The following is a description of a gene set: An array of kinases catalyze the reversible phosphorylation of nucleotide monophosphates to form nucleotide diphosphates and triphosphates.<p>Nucleoside monophosphate kinases catalyze the reversible phosphorylation of nucleoside and deoxynucleoside 5'-monophosphates to form the corresponding nucleoside 5'-diphosphates. Most appear to have restricted specificities for nucleoside monophosphates, and to use ATP preferentially (Van Rompay et al. 2000; Anderson 1973; Noda 1973). The total number of human enzymes that catalyze these reactions in vivo is not clear. In six cases, a well-defined biochemical activity has been associated with a purified protein, and these are annotated here. However, additional nucleoside monophosphate kinase-like human proteins have been identified in molecular cloning studies whose enzymatic activities are unknown, and several distinctive nucleoside monophosphate kinase activities detected in cell extracts, e.g., a GTP-requiring adenylate kinase activity and one or more guanylate kinase activities have not been unambiguously associated with specific human proteins.<P>The nucleoside monophosphates against which each of the six well-characterized enzymes is active is shown in the table (Van Rompay et al. 2000). All six efficiently use ATP as a phosphate donor, but have some activity with other nucleoside triphosphates as well in vitro. The high concentrations of ATP relative to other nucleoside triphosphates in vivo makes it the likely major phosphate donor in these reactions under most conditions.<P>All of these phosphorylation reactions are freely reversible in vitro when carried out with purified enzymes and substrates, having equilibrium constants near 1. In vivo, high ratios of ATP to ADP are likely to favor the forward direction of these reactions, i.e., the conversion of (d)NMP and ATP to (d)NDP and ADP. At the same time, the reversibility of the reactions and the overlapping substrate specificities of the enzymes raises the possibility that this group of reactions can buffer the intracellular nucleotide pool and regulate the relative concentrations of individual nucleotides in the pool: if any one molecule builds up to unusually high levels, multiple routes appear to be open not only to dispose of it but to use it to increase the supply of less abundant nucleotides.<p>Ribonucleotide reductase catalyzes the synthesis of deoxyribonucleotide diphosphates from ribonucleotide diphosphates. species: Homo sapiens Reactome Pathway: Interconversion of nucleotide di- and triphosphates part of: Metabolism of nucleotides, and this is the list of marker genes: DCTPP1, AK4, NME6, RRM2B, RRM2 (NCBI Gene Id 6241), DUT, CTPS2, AK9, GSR, NME2, NME1, GLRX, TYMS, CTPS1, TXN, AK6, AK2, AK5, GUK1, TXNRD1, AK7, NME4, AK1, DTYMK, NUDT13, RRM1, CMPK1 (NCBI Gene Id 51727, cytidine/uridine monophosphate kinase 1), NME3, AK8, DCTD